The following is a description of a gene set: Catalysis of the reaction: NAD(P)H + O2 = NAD(P)H + O2-. studied in species Mus musculus Mouse Gene Set: GOMF_SUPEROXIDE_GENERATING_NAD_P_H_OXIDASE_ACTIVITY, and this is the list of marker genes: Ncf1, Nox3, Ncf4, Nox4, Duox1, Sh3pxd2b, Nox1, Sh3pxd2a, Pdgfb, Cyba, Ncf2, Noxo1 (NADPH oxidase organizer 1), Duox2, Cybb, Noxa1